The following is a description of a gene set: Genes up-regulated in T reg from: peripheral lymph nodes versus thymic precursors. from publication Toker A, Engelbert D, Garg G, Polansky JK, Floess S, Miyao T, Baron U, Düber S, Geffers R, Giehr P, Schallenberg S, Kretschmer K, Olek S, Walter J, Weiss S, Hori S, Hamann A, Huehn J (PMID 23420886) studied in species Homo sapiens We investigated at which stage of maturation commitment to a stable Foxp3-expressing phenotype takes place. We assessed stability of Foxp3 expression in thymic Foxp3+ Treg subsets of different maturity, defined by CD24 expression. Next we compared gene expression profiles of Foxp3+ Treg subsets (+) of different maturity (24lo, 24int, 24hi) and could identify a set of genes that were specifically up or downregulated in Foxp3+ Tregs, but not in Foxp3- conventional T cells, in a maturation-dependent manner. Human Gene Set: GSE42021_TREG_PLN_VS_TREG_PRECURSORS_THYMUS_UP, and this is the list of marker genes: MUC2, MAVS, CFAP69, PLPP1, SNX13, TRIOBP, INPP5A, C11orf68, ZNF146, IQCG, EDN2, PHF7, FAT1, MACF1, CSPG4, SRSF8, UBL3, ANXA2P1, TNKS, ACTN2, PSMG2, PILRA, TMEM14B, MYH10, EPOR, OTUB2, RAC1, DYSF, CGRRF1, PPME1, STX6, OSBP, MECOM, FAM171A1, RRAD, IL7, OXTR, CUL3, RPL3L (NCBI Gene Id 6123), PHF20, SLC22A7, BCS1L (BCS1 homolog, ubiquinol-cytochrome c reductase complex chaperone), MYL5, CDR2 (cerebellar degeneration related protein 2), AGO2, SLC7A6, ZNF365, CRADD, TXLNG, PBX3, SLF2, POM121L9P, E2F2, GAS6, EXTL1, HOXA7, CCNT2, ATMIN, TROAP, ISCU, FAM13B, PGLYRP4, PLCB1, ACSL4, CD28, TRAK2, GPRC5B, NHERF4, SNHG20, TNFSF15, SZRD1, PAXIP1, FBXL14, MOAP1, COL17A1, ADAMTS13, TMEM120B, SLC25A32, NKRF, PRUNE1, LSG1, ZNF613, ITK, ATG14, H3C11, BHLHE41, AGAP1, KAZN, MS4A6A, KIAA0232, C1orf21, RAD54L, RGL1, FKBP15, RAB11FIP5, LIG4, PCDHB6, ODC1, CSH2, PDE10A, FAM200C, TOMM70, ZMYND8, NBEA, ZNRF4, HIGD1B, DCLRE1A, SLC25A14, MEGF9 (multiple EGF like domains 9), CPQ, WDR44, EFNB2, DIRAS2, PKP4, OLFML2B, PLEKHG3, AOX1, ING4, TCF21, SCGB2A2, HEY2, PADI3 (NCBI Gene Id 51702), HLA-F-AS1, MXD3, CARF, ABCA6, YARS2, NPRL3, MLXIP, MAN1A2, MLLT11, PRKACG, HEATR1, TRAPPC2, UROS, RHOBTB1, RGS3, MADD, TLX1, ICAM1, PI4KB, ACTA1, CERK, BFAR, HOPX, CCS, DPYS, MKRN3, TRPM3, RSBN1, GRB10, MYOM2, MYO19, ITGA10, MTPAP, GET1, SGCA, CEP192, EXO1, MZB1, TRMT61B, FLAD1, GIGYF2, CAMSAP1, SF3B1, NACC2, SERPINB5, SEZ6L, NSUN5, POU6F1, RAPGEFL1, KRTAP2-4, GRK6, TP73, VPS37B, BLM, WASF2, PRR14, MTMR3, PNMA8A, DPEP1, INPP5E, ATXN1, OSBPL11, ABCC4, TPX2, ZCCHC14, PCDHA9, BAG5, ATP2B1, MRTFB (NCBI Gene Id 57496), APLNR, SNAI2, FEN1, FOXO3, HPR, PALLD